The following is a description of a gene set: species: Mus musculus Mouse Gene Set: REACTOME_WNT5A_DEPENDENT_INTERNALIZATION_OF_FZD2_FZD5_AND_ROR2 WNT5A-dependent internalization of FZD2, FZD5 and ROR2, and this is the list of marker genes: Cltb, Clta, Cltc, Ror1, Fzd2, Wnt5a, Ap2s1, Fzd5, Ap2m1, Ap2b1, Ap2a2, Ap2a1